Given this list of marker genes WASF3, IGKV2D-40, IGKV1-39, WIPF3, IGLV3-19, LYN, MYO5A, IGLV2-23, CD247, IGHV3-48, IGKV3-11, IGHV1-46, MYO9B, IGLV11-55, IGHV3-33, IGHV3-30, IGLV7-46 (NCBI Gene Id 28775), IGLV3-27, NCKAP1L, SRC, IGLV3-1, IGHV, WASF1, MYO10, FCGR3A, NCK1, IGLV1-51, IGLC3, CYFIP2, IGHG2 (immunoglobulin heavy constant gamma 2 (G2m marker)), IGKV2-29, IGHG3, IGLV5-37, IGLC6, LPG1G2, RAC1, IGLC7, IGLV1-44, IGHV3-11, ARPC3, IGHG4, IGHV3-9, IGHV3-53, VAV3, BTK, IGLV3-12, WIPF1 (NCBI Gene Id 7456), IGHV4-34, ARPC2, MAPK1, ABL1, IGKV1-17, IGLV2-14, IGHV3-23, CRK, BRK1, IGKV1D-16, WASF2, NCKIPSD, NCKAP1, FYN, IGLV8-61, IGHV1-69, IGKV3-20, IGKV1D-39, IGKV1D-33, IGLC2, CDC42, IGKV1-33, IGKC, IGLC1, IGHG1, PTK2, IGLV7-43, IGLV3-16, IGLV1-47, IGKV2D-30, ARPC1A, WASL, CD3G, IGHV4-59, IGKV3D-20, IGLV2-33, IGLV2-18, IGKV3-15, GRB2, IGKV2-28, IGLV, IGLV2-11, YES1, IGLV2-8, IGHV2-70, IGLV5-45, IGHV4-39, FGR, BAIAP2, SYK, VAV1, VAV2, IGKV1-12, IGHV7-81, IGHV3-7, IGHV1-2, IGKV5-2, CYFIP1, WAS, ACTG1, IGKV1D-12, ARPC5, IGKV2-30, MAPK3, ARPC1B, ARPC4, DOCK1, ABI2, IGKV1-16, MYO1C, IGLV4-60, ACTB, IGLV3-25, IGHV2-5, MYH9, WIPF2 (WAS/WASL interacting protein family member 2), IGKV4-1, MYH2, IGLV6-57, IGLV3-22, IGKV1-5, IGLV3-21, IGKV2D-28, ABI1, IGLV1-40 (immunoglobulin lambda variable 1-40), ELMO2, IGLV1-36, HCK, IGHV3-13, IGLV10-54, IGLV4-3, ACTR2, IGLV4-69, ELMO1, ACTR3 (NCBI Gene Id 10096), here is a description of the gene set: species: Homo sapiens part of: Leishmania phagocytosis The Fc gamma receptors (FCGRs) have been reported to facilitate Leishmania internalization, especially when in its amastigote form. Following cell-to-cell propagation within an established infection or reinfection of a previously infected host, the IgG produced by the host covers the surface of Leishmania amastigote parasites, making them more susceptible to phagocytosis through FCGRs.<br><br>Classically, phagocytosis via FCGRs has been associated with the subsequent activation of Rac GTPases and Cdc42 which in turn activate the phagocyte's NADPH oxidase, contributing to the activation of killing mechanisms. Reactome Pathway: FCGR3A-mediated phagocytosis